Given this list of marker genes CD36, SCARB1, APP, LPL, CDH13, here is a description of the gene set: The series of molecular signals mediated by the detection of a lipoprotein particle. studied in species Homo sapiens Human Gene Set: GOBP_LIPOPROTEIN_PARTICLE_MEDIATED_SIGNALING